Given this list of marker genes GGCX, XYLT2 (xylosyltransferase 2), ABCC6, ENPP1, XYLT1, here is a description of the gene set: species: Homo sapiens Human Gene Set: HP_RETINAL_PEAU_D_ORANGE Retinal peau d'orange A pebbly orange appearance of the fundus that is said to resemble the skin of an orange.